Given this list of marker genes HKDC1, RBKS, NAGK, FGGY, PFKL, PFKFB1, GALK1, HK1 (hexokinase 1), XYLB (NCBI Gene Id 9942), HK3, PFKFB2, PFKFB4, GCK, HK2, KHK, PFKM, PFKP, PFKFB3, GALK2, POMK, GNE, here is a description of the gene set: Catalysis of the transfer of a phosphate group, usually from ATP, to a carbohydrate substrate molecule. studied in species Homo sapiens Human Gene Set: GOMF_CARBOHYDRATE_KINASE_ACTIVITY